The following is a description of a gene set: part of: Transport of Mature mRNAs Derived from Intronless Transcripts This event has been computationally inferred from an event that has been demonstrated in another species.<p>The inference is based on the homology mapping from PANTHER. Briefly, reactions for which all involved PhysicalEntities (in input, output and catalyst) have a mapped orthologue/paralogue (for complexes at least 75% of components must have a mapping) are inferred to the other species. electronically inferred by orthology from the curated human pathway Reactome Pathway: Transport of the SLBP independent Mature mRNA studied in species Mus musculus, and this is the list of marker genes: Nup93, Nup205, Nup58, Alyref (NCBI Gene Id 21681), Seh1l (SEH1-like (S. cerevisiae), Ndc1, Nup85, Nup133, Aaas, Nup155, Nup42, Nup210, Rae1, Nup54